The following is a description of a gene set: Mouse Gene Set: GOBP_FATTY_ACID_ALPHA_OXIDATION A metabolic pathway by which 3-methyl branched fatty acids are degraded. These compounds are not degraded by the normal peroxisomal beta-oxidation pathway, because the 3-methyl blocks the dehydrogenation of the hydroxyl group by hydroxyacyl-CoA dehydrogenase. The 3-methyl branched fatty acid is converted in several steps to pristenic acid, which can then feed into the beta-oxidative pathway. studied in species Mus musculus, and this is the list of marker genes: Slc27a2, Pex13, Phyh, Hao1, Ilvbl, Hacl1